Given this list of marker genes IDH2, TMBIM4, PPAN, WAS, LMCD1, BCL7A, MDGA1, PLCD4, NR2F6, CBR1, DLX2, CC2D2A (NCBI Gene Id 57545), LTB4R2, IER5L, PSMB10, SPTSSB (NCBI Gene Id 165679), PCDHA12, LGI3, MRPS30, MRPS16, SPMIP4, STMN4, RPF2, RAB3B, PHYKPL, PFKM, MRPL34, APLN, YBX3, FNDC7, CHCT1, MYL4, GCM1, RANBP17, GGACT, EEF1AKMT2, XRCC6, RPLP2, SPATA24, C8B (complement C8 beta chain), UQCR10, SMOX, PLCD3, CETN2, LIF, CFAP298 (NCBI Gene Id 89757), SYCE2, CRB1, MORN2, QTRT1, PNO1, SCNN1G, C6orf15, SS18L2, ORC6, POLR1H, IFT27, AMBN, TSFM, DYNC2I2, FKBP11, NDUFAF1, WDR77, SPINT1, CDH4, BID, MBIP, NFAM1, CLMP, LSM11, PLAC8L1, NDUFS3, MTHFD1L, PLCXD1, CCDC40, SPINDOC, MRPS31, BSN, PITX3, CHURC1, FES, MRPL42, LAMTOR4, CD320, SYTL1, HACD1, C12orf50, OSTF1, EFNA2, TNNC2, SLC25A12, UBE2T, LRPPRC, GNPTG, MRPS33, MAFK, TMCO6, COMTD1, EIF3M, MRPL32, HSF1, GPSM3, MPND, RTCA, SPTSSA, SLC26A8, GPC1, MRPS9, UPP1, OSGEPL1, CARNMT1, MGARP, SLIT3, GP6, SREK1IP1, MRPS14, COL22A1, MRPL24, NECTIN2, PSMA5, CITED2, CLPB, SOX9 (SRY-box transcription factor 9), MMEL1, COPE, CDH2, COMMD1, MCRIP2, RUVBL1, KCNMB4, KGD4, COQ5, GINS2, CD74, ARHGEF10L, PTGIS, MT3, PDE6D, ATP2A1, IL1R1, C1orf174, TICAM1, GUSB, MIX23, PTPRCAP, LTBP3, CNMD, GPR45, NAB2, MRPL23, KCNQ5, KAT8, AIG1, CENPW, FANCF, AKR7A2, TERB1, SELENBP1, ABCC5, ROM1, MRPL16, KLK8, RPP21, ASTL, SDF2L1, DZIP1L, EYA2, SLC4A10, DDX59, NAGS, STOML2, PPP2R5A, TNFRSF4, CDHR3, CD247, RXRA (NCBI Gene Id 6256), CASP1, SASH1, ZNF76, LGALS3BP, TMEM107, NDUFB3, KDELR3, MRPL19, UQCC6, TRNAU1AP, FBXO7, MRPS35, SAP130, HDAC2, AK2, LYRM4, MPLKIP, RFC5, CBR3, MRPL28, NFKBIB, TMEM39A, LRAT, CA7, here is a description of the gene set: from publication Lee Y, Awasthi A, Yosef N, Quintana FJ, Xiao S, Peters A, Wu C, Kleinewietfeld M, Kunder S, Hafler DA, Sobel RA, Regev A, Kuchroo VK (PMID 22961052) Genes down-regulated in comparison of CD4 T cells treated with TGFB3 and IL6 versus those treated with TGF3B, IL6 and IL23A. species: Homo sapiens Human Gene Set: GSE39820_TGFBETA3_IL6_VS_TGFBETA3_IL6_IL23A_TREATED_CD4_TCELL_DN TGF-beta3 produced by developing Th17 cells induces highly pathogenic T cells that are functionally and molecularly distinct from TGF-beta1-induced Th17 cells. The microarray data represent a distinct molecular signature for pathogenic versus non-pathogenic Th17 cells.